Given this list of marker genes MPHOSPH6, RHOBTB3, BHLHE41, SAMSN1, ZNF676, TOR1A, HNRNPD, ZNF493, FZD1, KCNJ16, CXXC4, RARB, DCDC1, YES1, CASP7, APPL1 (adaptor protein, phosphotyrosine interacting with PH domain and leucine zipper 1), NEB, C9orf72, EIF4G2, VPS54, TCF20, VASN, SLC12A6, SRP72, ZNF649, SORT1, ZNF275, SRSF6, RPF1, UPP2, ZNF652, MAP3K8, YWHAB, CTAGE9 (CTAGE family member 9), THAP5, USP6, FLNA, WWC2, NEMP1, FLOT2, ZNF136, FBXO4, IRAK1, GDAP1L1 (NCBI Gene Id 93987), MMP16, SIAH2, TMEM120B, TRAF6, LRRTM2, ERBB4, GRIA3, TMEM19, ZFYVE1, LANCL1, ZBTB2, ZNF506, HIPK3, MRS2, DCAF12, PLSCR4, LRP2, PPBP (pro-platelet basic protein), MOCS2, CD96, ABL2, ZNF540, GATAD1, CCL5, MBNL3, CYP27B1, NUMB, CXADR, LRCH1, CD80, C3orf38, CARD10, ZNF257, FBXW2, GPM6B, PPP1R11, NOS1, ZNF253, ZNF354B, USP32, CDKN2AIP, CNTF, TDRKH, BRK1, SLC10A3, NOVA1, PAQR5, COLEC10, MARCHF6, SRD5A2, SLC38A1, BCORL1, BIVM, DDHD1, ZNF662, CTAGE8, FOXR2, POFUT2, CPM, PPM1K (NCBI Gene Id 152926), CCK, ARL10, MED20, ZNF90, SHCBP1 (NCBI Gene Id 79801), MED1, SLC16A14, STRBP, PTPRA, SEC23IP, CTAGE4, C8orf88, AMPH, here is a description of the gene set: Human Gene Set: MIR7153_5P Genes predicted to be targets of miRBase v22 microRNA hsa-miR-7153-5p in miRDB v6.0 with MirTarget v4 prediction scores > 80 (high confidence targets). species: Homo sapiens from publication Chen Y, Wang X (PMID 31504780)